The following is a description of a gene set: species: Mus musculus Any process that modulates the frequency, rate, or extent of a series of reactions, mediated by the intracellular serine/threonine kinase protein kinase C, which occurs as a result of a single trigger reaction or compound. Mouse Gene Set: GOBP_REGULATION_OF_PROTEIN_KINASE_C_SIGNALING, and this is the list of marker genes: Vegfa, Gpd1l (NCBI Gene Id 72363), Flt4, Wnt5a, Phlpp1, Cd40, Wnt11, Myadm, Pla2g6, Akap12 (A kinase anchor protein 12), Adra1a